Given this list of marker genes TXN2, HNRNPU, SLAMF8, CNTNAP3, GAB4, TTC14, LBP, BACE2, PRICKLE2, BHLHE22, AMOT, RNF215, CAPN5, NUFIP2, BCAS2, ZNF99, LIAT1, ZNF138, KANK1, ZNF208, H2BC12, STK16, KPNA1, TMEM47, CYTH4, THRB, FLCN, ANKRD49, CDH22, SEMA3C, GLUD1, CNTNAP3B, RNF146, ZNF264, TADA2B, TMEM165, here is a description of the gene set: Human Gene Set: MIR4751 Genes predicted to be targets of miRBase v22 microRNA hsa-miR-4751 in miRDB v6.0 with MirTarget v4 prediction scores > 80 (high confidence targets). from publication Chen Y, Wang X (PMID 31504780) species: Homo sapiens